The following is a description of a gene set: part of: Diseases associated with glycosylation precursor biosynthesis Reactome Pathway: Defective DPM1 causes DPM1-CDG studied in species Homo sapiens Dolichyl-phosphate mannosyltransferase (DPM), a heterotrimeric protein embedded in the endoplasmic reticulum membrane, mediates the transfer of mannose (from cytosolic GDP-mannose) to dolichyl phosphate (DOLP) to form dolichyl-phosphate-mannose (DOLPman). The first subunit of the heterotrimer (DPM1) appears to be the actual catalyst, and the other two subunits (DPM2 and 3) appear to stabilise it. Defects in DPM1 can cause congenital disorder of glycosylation 1e (DPM1-CDG, CDG-1e; MIM:608799), a multisystem disorder caused by a defect in glycoprotein biosynthesis and characterised by under-glycosylated serum glycoproteins., and this is the list of marker genes: DPM1, DPM3, DPM2